The following is a description of a gene set: species: Homo sapiens Human Gene Set: GOBP_PRESYNAPTIC_MEMBRANE_ASSEMBLY The aggregation, arrangement and bonding together of a set of components to form a presynaptic membrane, including any proteins associated with the membrane, but excluding other cellular components. A presynaptic membrane is a specialized area of membrane of the axon terminal that faces the plasma membrane of the neuron or muscle fiber with which the axon terminal establishes a synaptic junction., and this is the list of marker genes: PTPRD, LRP4, PTEN, NRXN1, NLGN4X, NLGN2 (neuroligin 2), IL1RAPL1, NLGN3, NLGN1